The following is a description of a gene set: Human Gene Set: GOBP_RESPONSE_TO_L_ASCORBIC_ACID Any process that results in a change in state or activity of a cell or an organism (in terms of movement, secretion, enzyme production, gene expression, etc.) as a result of an L-ascorbic acid (vitamin C) stimulus. species: Homo sapiens, and this is the list of marker genes: GSTP1, LEP, ITGA2, CAT, SOD2 (superoxide dismutase 2)